The following is a description of a gene set: studied in species Homo sapiens A deviation from the normal count of erythroid precursor cells, that is, erythroid lineage cells in the bone marrow. Human Gene Set: HP_ABNORMAL_NUMBER_OF_ERYTHROID_PRECURSORS Abnormal number of erythroid precursors, and this is the list of marker genes: RPS14, RPS26, PIGA, KLF1, PUS1, RPS27, CDIN1, PNP, TSR2, RPL31, PGK1, RPL27, RPS7, RPS29, RPS24, HBB, TCN2, RPL8, RPL18, ADA2, UROD, SF3B1, RPL35A, RPL35, RPL5, SLC11A2 (NCBI Gene Id 4891), RPS17, HEATR3, LPIN2, RPS20, RPL26, GLRX5, CTLA4, LARS2, UROS, RPL11, TET2, RPS19, RPL15, ABCB7, G6PC3, TP53, PKLR, ERBB3, RPS10, CDAN1, CBLIF, RPS28, EPO, RPL9, RPS15A, GATA1